Given this list of marker genes TXNL4A, MYCBP2, RNF6, PITRM1, PTEN, ATAD1, ESD, MED4, PROSER1, PRKN, NUFIP1, BAG5, PACRG, SAP18, MARK3, SUCLA2, ALG5, CRYL1, LPAR6 (NCBI Gene Id 10161), SPART, MTMR6, EIF3J, B2M, ATP5MJ, KLF6, FNDC3A, WWOX, RPL21, PFKP, TPT1, SERF2, MBP, CLN5, ELL3, MAF, MFAP1, RCBTB1, PAPSS2, PDIA3, KPNA3, CDKN2A, here is a description of the gene set: The classification of human tumors based on molecular criteria offers tremendous clinical potential; however, discerning critical and druggable effectors on a large scale will also require robust experimental models reflective of tumor genomic diversity. Here, we describe a comprehensive genomic analysis of 101 melanoma short-term cultures and cell lines. Using an analytic approach designed to enrich for putative driver events, we show that cultured melanoma cells encompass the spectrum of significant genomic alterations present in primary tumors. When annotated according to these lesions, melanomas cluster into subgroups suggestive of distinct oncogenic mechanisms. Integrating gene expression data suggests novel candidate effector genes linked to recurrent copy gains and losses, including both phosphatase and tensin homologue (PTEN)-dependent and PTEN-independent tumor suppressor mechanisms associated with chromosome 10 deletions. Finally, sample-matched pharmacologic data show that FGFR1 mutations and extracellular signal-regulated kinase (ERK) activation may modulate sensitivity to mitogen-activated protein kinase/ERK kinase inhibitors. Genetically defined cell culture collections therefore offer a rich framework for systematic functional studies in melanoma and other tumors. from publication Lin WM, Baker AC, Beroukhim R, Winckler W, Feng W, Marmion JM, Laine E, Greulich H, Tseng H, Gates C, Hodi FS, Dranoff G, Sellers WR, Thomas RK, Meyerson M, Golub TR, Dummer R, Herlyn M, Getz G, Garraway LA (PMID 18245465) species: Homo sapiens Candidate genes in significant regions of chromosomal copy number losses in a panel of melanoma samples. Human Gene Set: LIN_MELANOMA_COPY_NUMBER_DN